The following is a description of a gene set: Agenesis of one or more central incisors, i.e., of lower secondary incisor, lower primary incisor, upper secondary incisor, or of upper central primary incisor. Agenesis of central incisor Human Gene Set: HP_AGENESIS_OF_CENTRAL_INCISOR studied in species Homo sapiens, and this is the list of marker genes: LRP6, MSX1, NEK1, EIF4A3, FGFR1, AXIN2, EDARADD, IRF6, EDA, WNT10B, PAX9, SUMO1, TGFA, WNT10A